The following is a description of a gene set: studied in species Mus musculus from publication Chen Y, Wang X (PMID 31504780) Mouse Gene Set: MIR_3470A Genes predicted to be targets of miRBase v22 microRNA mmu_miR_3470a in miRDB v6.0 with MirTarget v4 prediction scores > 80 (high confidence targets)., and this is the list of marker genes: Igsf6, Ptprt, Sar1a, Emx2 (NCBI Gene Id 13797), Nfatc2, Tent5a (NCBI Gene Id 320335), Slc12a6, Zfp825, Atg16l2, Gpbp1l1 (GC-rich promoter binding protein 1-like 1), Ncoa4, Ccn1, Zfp521, Ppp6r3, Pcdhb10, Ulk2, Scpep1, Ntrk2, Fzd7, St3gal1, Arrdc3, Nras, Plcl1, Ikbip, Mfap3, Pms1, Atf2, Smco4, Nr2e1, Socs2, Ncapg2, Pde4d, Fktn, Cyp2j13, Flrt3, Slc4a7, Cggbp1 (CGG triplet repeat binding protein 1), Chd7, Slc12a2 (solute carrier family 12, member 2), Kremen2, Retreg1, Ubtfl1, Myo1e, Xpo1, Clec1a, R3hdm1, Psmd14, Zbed6, Cdh2, Bbx (NCBI Gene Id 74503), Sos2, Prxl2a, Gdi1, Gemin8, Srprb, Septin9, Fbxo33, Samd8, Zfp292, Spock3, Dido1, Lin54, S1pr1, Ccdc90b, Gsc, Edil3, Lrrc19, Zfp281, Ano5, Adcy7, Sspn, Adgrf1 (NCBI Gene Id 77596), Krcc1, Rwdd3, Atl3, Uri1, Hoxa4, Sgsm2, Ppp1r14c, Hsbp1, Zgpat, Cln5, Ctps2, Oaz1, Prkar2a, Rfx7, Zfp704, Maged1, Ankrd33, Zc3h6, Snap91, Jam2, Kcne4, Pdcd1lg2, Fign, Ribc2, Mex3a, Etnppl, Rcc2, Tusc3, Bmal1, Insig1, Yme1l1, Heg1, Asxl2, Ccdc88a, Tmcc1, Dnajc18, Mga, Pof1b, Racgap1, Ell2, Zfp512b, Reep5, Trip12, Serp1, Npr3, Dek, Snap25, Erlin1, Gramd1c, Ripor2, Pdik1l, P2ry10b, Pde5a, Hnrnph2, Zfp423, Tead1, Nedd4l, Onecut2, Prdm8, Wdr43, Sytl5, Paics, Csf2rb, Erich5, Nceh1, Tmem127, Dtd2, Cpne3